Given this list of marker genes HBEGF, HEY1, NR4A1, ZFP36, FOSB, ELN, DUSP6, BHLHE40, BTG2, KLF4, GADD45B, NFKBIZ, IER3, JUNB, SIAH2, NFIL3, EGR2, KLF9 (NCBI Gene Id 687), KLF10, GADD45G, ERRFI1, here is a description of the gene set: from publication Geserick C, Tejera A, González-Suárez E, Klatt P, Blasco MA (PMID 16501597) Here, we show that ectopic expression of the catalytic subunit of mouse telomerase (mTert) confers a growth advantage to primary murine embryonic fibroblasts (MEFs), which have very long telomeres, as well as facilitates their spontaneous immortalization and increases their colony-forming capacity upon activation of oncogenes. We demonstrate that these telomere length-independent growth-promoting effects of mTert overexpression require catalytically active mTert, as well as the formation of mTert/Terc complexes. The gene expression profile of mTert-overexpressing MEFs indicates that telomerase enhances growth in these cells through the repression of growth-inhibiting genes of the transforming growth factor-beta (TGF-beta) signaling network. We functionally validate this result by showing that mTert abrogates the growth-inhibitory effect of TGF-beta in MEFs, thus demonstrating that telomerase increments the proliferative potential of primary mouse embryonic fibroblasts by targeting the TGF-beta pathway. Human Gene Set: GESERICK_TERT_TARGETS_DN Genes down-regulated in MEF cells (embryonic fibroblasts) with TERT knockout, after expression of the gene off a retroviral vector. species: Mus musculus